Given this list of marker genes MAP3K14, UPB1, VDR, TRAF5, TYROBP, SLC41A2, APOBR, SLAMF9, IL18RAP, KCTD10, HHEX, CTSW, SNX10, N4BP2L2, MPEG1, TTC27, FAM234A, ZXDC, FGL2, HS3ST3B1, FNDC3B, RNFT1, CORO2A, RPRD2, MAGEB16, LAIR1, RCN1, PARP8, UTP4, CLEC4M, PLXNC1, MAN1C1, EHBP1L1, CYTH4, RFLNB (NCBI Gene Id 359845), IRF9, GZMB, NTRK3, SCYL3, GDI2, RIPK1, BHLHE40, CLEC10A, TMIE, IFI44, GM2A, ACSBG1, HLA-B, GUCD1, IL18R1, GOLM1, PCED1A, MPPE1, INPP5E, TRMT2B, RHOQ, MMD, SDC4, GALNT9, PEA15, MARVELD2, RNF115, INTS4, CEMIP2, RIN2, DNAJA4, SLC35A3, LGALS3BP, SCFD1, PRMT3, PRXL2C, TOR3A, UBASH3B, KCNN2, SNTB2, NOXRED1, SEC24D, TNFSF14, TEX2, TENT5A, TTC39B, ADGRE5, CD44, IRF8, SPRY2, SDCBP2, TBC1D5, BANK1, VIT, CAMK2D, EVI2B, IFITM10, EVL, ABTB3, APP, HOPX, TMEM71, RHOC, HS3ST1, TRPM6, CYBB, C19orf12, PEPD, NIBAN1, AHNAK, NLN, ZC3H12C, SMPDL3A, IER5, SLC17A9, IL2RB (NCBI Gene Id 3602), TDRD7, KLRK1, LITAF, CASP1, ADGRG5, ZNF536, CD68, CXCR3, GID4, RRM2B, ATP10D, DNAH8 (dynein axonemal heavy chain 8), ITGA4, ST8SIA6, SRPK3, ZC3H12D, RHOB, TAGAP, LIF, NUCB2, FAM43A, TF, SGK1, RXRA, DHDH, GGT1, VMP1, GEM, CCND1, RRP1B, MX2, MAF, HPSE, B4GALNT4, FAF2, FAAH, PLTP, TLR1, CXCR5 (NCBI Gene Id 643), SIDT1, GNE, S1PR4 (sphingosine-1-phosphate receptor 4), CDH1, MAP3K5, PRKCD, PLEK, CYP4V2, ANKH, ALCAM, ITGAE, PTPN3, KLRD1, DAAM1, CERS4, TASL (TLR adaptor interacting with endolysosomal SLC15A4), NKG7, RNF144A, CD38, IRF7, C5, PGAP6, FAM167A, PRG4, IL1RL1, DSE, COQ8A, SYNE2, TBX21, EOMES, TRAF3IP2, ATP8B4, IRAK4, STAT4, CD200R1L, CYB561A3, EPHX1, IFNG, NT5E, GRN, CLOCK, ERO1A, LY86, ATP8A2, XDH, D2HGDH, NCF4, MROH1, LDLRAP1, OAS1, here is a description of the gene set: studied in species Homo sapiens After positive selection in the thymus, the newly generated single positive (SP) thymocytes are phenotypically and functionally immature and undergo apoptosis upon antigen stimulation. In the thymic medullary microenvironment, SP cells progressively acquire immunocompetence. Negative selection to remove autoreactive T cells also occur at this stage. We have defined four subsets of CD4 SP, namely, SP1, SP2, SP3, and SP4 that follow a functional maturation program and a sequential emergence during mouse ontogeny.We used microarray to detail the global programm of gene expression during the maturation of murine CD4 single positive thymocytes from publication Teng F, Zhou Y, Jin R, Chen Y, Pei X, Liu Y, Dong J, Wang W, Pang X, Qian X, Chen WF, Zhang Y, Ge Q (PMID 22022412) Human Gene Set: GSE30083_SP3_VS_SP4_THYMOCYTE_DN Genes down-regulated in comparison of SP3 thymocytes versus SP4 thymocytes.